The following is a description of a gene set: Human Gene Set: GOBP_SKELETAL_MUSCLE_ACETYLCHOLINE_GATED_CHANNEL_CLUSTERING The accumulation of acetylcholine-gated cation channels in a narrow, central region of muscle fibers, in apposition to nerve terminals. species: Homo sapiens, and this is the list of marker genes: ETV5, CRK, DVL1, RER1, MESD, RAC1, CRKL, COLQ (collagen like tail subunit of asymmetric acetylcholinesterase), FZD9, RAPSN, FNTA (NCBI Gene Id 2339), DOK7 (NCBI Gene Id 619409), DNAJA3, MUSK, LRP4, FARP1